Given this list of marker genes Commd1 (NCBI Gene Id 17846), Rab11a, Arhgap44, Rab8a, Lrrc7, Snx27, Washc1, Gripap1, Scrib, Vps35, Grip1, Zdhhc2, Akap5, Sorl1, Trarg1, Atp6ap1, Rab7, Nsg1, Scarb2, Myo5b, Grip2, here is a description of the gene set: Mouse Gene Set: GOBP_ENDOSOME_TO_PLASMA_MEMBRANE_PROTEIN_TRANSPORT species: Mus musculus The directed movement of proteins from the endosome to the plasma membrane in transport vesicles.